The following is a description of a gene set: Human Gene Set: AAGCAAT_MIR137 Genes having at least one occurence of the motif AAGCAAT in their 3' untranslated region. The motif represents putative target (that is, seed match) of human mature miRNA hsa-miR-137 (v7.1 miRBase). studied in species Homo sapiens, and this is the list of marker genes: NAB2, YBX3, RSBN1, MED1, MSI1, DYRK1A, FNBP1L, TLE4, CPSF6, CACNA1G, SMC1A, PPM1E, SOX11, PDCD6, LURAP1L, DMRT2, INPP5A, PICALM, EIF4A2, CDC37L1, HERPUD2, NRP1, CCZ1, HLF, CUL4A, UBR3, ARB2A, RHOBTB1, RPS13, PPP3CB, RIMS3, RNF128, SPHK2, GPCPD1, NOVA1, CA7, CSMD2, NABP1, TRIM33, NREP, MIB1, HMCN1, ZNF385A, PPP5C, FLRT3, ARHGEF7, MED14, NEUROD1, PTGFRN, RPGRIP1L, RAP2C, SNX25, MAPK1IP1L, SETD7, SATB1, DIP2B, ZMYND11, ACP1, CDIN1, BSN, DUSP8, MAML3, MGAT5B, ARK2N, FLRT2, KMT2A, KANK4, RANBP2, RIMS4, MINAR1, DNAJB1, EPHA7, STC1, CCZ1B, ZDHHC5, SHANK2, FURIN, ANKRD12, KCNB2, SLC17A6, CLPX, HNRNPDL, SNRK, NR3C2, SHROOM2 (shroom family member 2), DEXI, RTL3, PLAGL2, ZMYM2, PIP4P2, RAVER2, YOD1, ERBB4, ASPH, TARDBP, RC3H1, CHORDC1, RGS7BP, ZFC3H1, TSC22D2, SH3BP5 (SH3 domain binding protein 5), GPR88, RBMS3, MEIS2, MAB21L2, SRSF5, RBM12, RELL2, MITF, PALM2AKAP2, EPHA4, KCNA2, RAB35, SIK1, MCU, RBM26 (RNA binding motif protein 26), CTTNBP2NL, RETREG3, PDE4A, BACH2, CREBBP, SGCD (sarcoglycan delta), XPO4, PRDM1, CDC42, FAM117B, SYNC, FAM222B, ATOH8, RORB, UBE2H, CTLA4, ABHD6, CCNG2, KLHL10, TBC1D19, SRGAP3, RFX4, DPYS, SLC43A2, RUNX2, SLC24A3, SCRT2, PDLIM3, DIO2, KDM2A, ST18, SLC46A3, WIF1, PPP4R3A, AP1G1, NFASC, SRPK1, SYT1, SOBP, GRIN2A, PPARGC1A, WSB1, CTDSP2, SLC6A6, KLF12, NKAIN1, SON, OGT, EIF2S3, MSANTD2, RNF138, PLEC, EGR2, PWWP3B, MYBPC1, QKI (NCBI Gene Id 9444), DR1, DIPK2A, MORC4, CADPS, ARID4B, BMPR2, DCDC2, NKAPD1, CUL3, MAPKAPK2, MMP16, SLC25A5, MTPN, ESRRG, RBMXL1, THBS4, MED13, ZC3H6, CHST9, SERP1, CTDSPL, SLC7A9, CBLN2 (cerebellin 2 precursor), CC2D2B, PRR16, CEP128, CCNY, METTL9, ESRRA, WNK4, OXR1, AMD1, LIMCH1, SGPL1, PHLPP2, PTPN2, ADCY1, ST3GAL3, ATP1B1, LBX1, DDX3X, RAB21, FMNL2, RCN1, PLCB1, FNDC3A, GREM1, FBXL7, NPEPL1, TSSK3, STX16